Given this list of marker genes REN, NPHP3, AGT, AIP, PAX2, FGF20, MAN2B1, GPR101, HIBCH, UBA1, PBX1, CEP55, ITGA8, ACE, GFRA1, AGTR1, PKHD1, here is a description of the gene set: Human Gene Set: HP_FACIAL_SHAPE_DEFORMATION studied in species Homo sapiens Facial shape deformation